The following is a description of a gene set: species: Homo sapiens Pruritus is an itch or a sensation that makes a person want to scratch. This term refers to an abnormally increased sensation of itching over the palm(s) of the hand. Human Gene Set: HP_PALMAR_PRURITUS Palmar pruritus, and this is the list of marker genes: CFTR, ATP8B1, ABCB4, ABCB11, NR1H4